Given this list of marker genes NOS1, CRLF1, FOXP3, HLA-DQB1, HLA-DQA1, here is a description of the gene set: Human Gene Set: HP_DECREASED_CIRCULATING_PREALBUMIN_CONCENTRATION Concentration of prealbumin in the blood circulation below the lower limit of normal. Prealbumin, also known as transthyretin, has a half-life in plasma of about 2 days, much shorter than that of albumin. Prealbumin is therefore more sensitive to changes in protein-energy status than albumin, and its concentration closely reflects recent dietary intake rather than overall nutritional status. Decreased circulating prealbumin concentration studied in species Homo sapiens